The following is a description of a gene set: from publication Gavish A, Tyler M, Greenwald AC, Hoefflin R, Simkin D, Tschernichovsky R, Galili Darnell N, Somech E, Barbolin C, Antman T, Kovarsky D, Barrett T, Gonzalez Castro LN, Halder D, Chanoch-Myers R, Laffy J, Mints M, Wider A, Tal R, Spitzer A, Hara T, Raitses-Gurevich M, Stossel C, Golan T, Tirosh A, Suvà ML, Puram SV, Tirosh I (PMID 37258682) Genes upregulated in subsets of cells of a given type within various tumors Human Gene Set: GAVISH_3CA_METAPROGRAM_CD8_T_CELLS_NAIVE_2 In this study, an extensive analysis was conducted to define meta-programs (MPs) capturing intra-tumor heterogeneity across a spectrum of tumor types. The approach utilized non-negative matrix factorization (NMF) to analyze each cell type separately within individual tumor samples. This involved the analysis of malignant cells, macrophages, fibroblasts, endothelial cells, epithelial cells, T-cells, and B-cells. NMF was executed with varying parameter values (K=4, 5, 6, 7, 8, 9), thereby generating 39 programs for each cell type per sample. Each NMF program was summarized by the top genes based on NMF coefficients.\nRobust MPs were then delineated for each cell type using a set of stringent criteria, including recurrence within the same tumor, similarity to programs in other tumors, and non-redundancy within a tumor. Subsequently, these robust NMF programs were clustered (per cell type) based on Jaccard similarity, leading to the identification of MPs associated with each cell type.\nTo enhance the quality of the MPs, a refinement steps were undertaken, involving the removal of MPs suspected of reflecting low-quality data (with an overrepresentation of ribosomal proteins or mitochondrial-encoded genes), single-study inclusion, or similarity to miss-annotated cell types. species: Homo sapiens, and this is the list of marker genes: ALKBH7, ERP29 (NCBI Gene Id 10961), TMEM123, TCF7, RSL1D1, LDLRAP1, AQP3, EIF3E, SNHG7, EIF3L (NCBI Gene Id 51386), SATB1, PRMT2, LEF1, CD27, LTB, NOSIP, SNHG32, PIK3IP1, FOXP1, CD55, LDHB, RASGRP2, NDFIP1, NUCB2, MYC, GIMAP1, CCR7, PHB2, UXT, KLF2, TXK, MAL, TRAT1, SORL1, SNHG8, AIF1, EIF3D, PRKCQ-AS1, PLAC8, EIF2S3, RIPOR2, TXNIP, IL7R, PPA1, SELL, PRKCA, RCAN3, ATP5F1A, FCMR, ST13